Given this list of marker genes Fgfr1, Ddr2, Esm1, Flt1, Ptpn2, Stmn1, Erbb4, Ephb1, Igf1r, Pak1, Epha5, Insr, Ephb3 (Eph receptor B3), Pdgfra, Erbb2, Pdgfrb, Egfr, Ptpn1, Ephb2, Tie1, Met, Epha3, Kit, Epha6, Epha1, Ntrk2, Fgfr4, Fgfr3, Epha7, Adamts12, Mertk, Ddr1, Bcar1, Fgfr2, Rac1, Alk, Tek, Ret, Epha10, Axl (AXL receptor tyrosine kinase), Nrp1, Flt3, Ros1, Epha2, Epha8, Insrr, Muc20 (NCBI Gene Id 224116), Ntrk1, Flt4, Ephb4, Hgf, Csf1r, Kdr, Tyro3, Mst1r, Musk, Epha4, Ntrk3, Ltk, Ror2, here is a description of the gene set: Mouse Gene Set: GOBP_HEPATOCYTE_GROWTH_FACTOR_RECEPTOR_SIGNALING_PATHWAY species: Mus musculus The series of molecular signals initiated by a ligand binding to a hepatocyte growth factor receptor, and ending with the regulation of a downstream cellular process, e.g. transcription.